The following is a description of a gene set: Activating mutations in the juxtamembrane domain of KIT are common in some cancers, including gastrointestinal stromal tumors, melanoma and acute myeloid leukemia. These mutations are sensitive to inhibition with imatinib, which in 2001 was the first tyrosine kinase inhibitor approved for treatment of cancer. Although highly successful in prolonging survival, imatinib-resistance develops in most patients due to appearance of secondary mutations, often in the ATP-binding pocket or in the activation loop of the kinase domain part of: Signaling by KIT in disease Reactome Pathway: Drug resistance of KIT mutants species: Homo sapiens, and this is the list of marker genes: KIT